Given this list of marker genes RABGEF1, SYNJ1, NPEPPS, ATP6V1F, UBE4A, MRC2, NEDD9, UBN2, CNTF, FEZF2, KLF6, CAPZA1, LYN, VCF1, NPY2R, C2orf49 (chromosome 2 open reading frame 49), CDKN2B, LRPAP1 (NCBI Gene Id 4043), SRSF10, DNM3, NCR3LG1, YWHAE, ADGRG2, GLUD1, RALGPS1, RCAN1, LMNA, LHX2, LRIG1, KBTBD2, LRBA, FBXW7, ARHGAP32, NAV1, here is a description of the gene set: Human Gene Set: MIR6819_3P studied in species Homo sapiens Genes predicted to be targets of miRBase v22 microRNA hsa-miR-6819-3p in miRDB v6.0 with MirTarget v4 prediction scores > 80 (high confidence targets). from publication Chen Y, Wang X (PMID 31504780)